Given this list of marker genes WARS1, XBP1, BCL2L11, EIF2A (NCBI Gene Id 83939), ATF6, ATF4, DNAJC3, ERN1, DNAJB9, DNAJB11, ERP27, UBE2E1, NFE2L2, ATF3, PDIA6, PPP1R15A, TRIB3, EDEM1, NARS1, ASNS, HSPA5, SULT1E1, CALR, BBC3, DDIT3, HSP90B1, EIF2AK3, here is a description of the gene set: Human Gene Set: WP_PHOTODYNAMIC_THERAPYINDUCED_UNFOLDED_PROTEIN_RESPONSE studied in species Homo sapiens Photodynamic therapy-induced unfolded protein response